Given this list of marker genes Fgf14, Cacnb3, Calm3 (calmodulin 3), Dysf, Sri, Calm1, Nipsnap2, Cacnb2, here is a description of the gene set: Any process that modulates the frequency, rate or extent of high voltage-gated calcium channel activity. species: Mus musculus Mouse Gene Set: GOBP_REGULATION_OF_HIGH_VOLTAGE_GATED_CALCIUM_CHANNEL_ACTIVITY